The following is a description of a gene set: Human Gene Set: HP_SECONDARY_HYPERPARATHYROIDISM studied in species Homo sapiens Secondary hyperparathyroidism Secondary hyperparathyroidism refers to the production of higher than normal levels of parathyroid hormone in the presence of hypocalcemia., and this is the list of marker genes: VDR, PHEX, CA2, CYP27B1, CYP2R1, ANKH